The following is a description of a gene set: species: Homo sapiens Human Gene Set: ZBTB49_TARGET_GENES Genes containing one or more binding sites for (ZBTB49) in their promoter regions (TSS -1000,+100 bp) as identified by GTRD version 20.06 ChIP-seq harmonization. from publication Yevshin I, Sharipov R, Kolmykov S, Kondrakhin Y, Kolpakov F (PMID 30445619), and this is the list of marker genes: PSMD9, TBL1X, LGALS2, TUBA1B, SNUPN, MIR615, TUBA1B-AS1, RDH12, GALM, PNKP